Given this list of marker genes NFKBIA, DHRS3, ADCY1, NR4A3, PTGDS, ICAM1, CXCL3, SNED1, COL21A1, CXCL8, GCH1, MAP3K8 (NCBI Gene Id 8040), ADH1B, EGR1 (early growth response 1), FYB1, ADH1C, ATF3, CFD, APOE, CHRDL1, VWA5A, SLC29A1, SSX2, RARRES2, IGF2, TMEM265, RGS2, ATP1A2, ERP44, NR4A1, ECPAS, MFAP4, DAZL, NR4A2, ELANE, ADH1A, IRF1, FOS, N4BP2L1, ECM2, here is a description of the gene set: studied in species Homo sapiens Genes up-regulated in primary fibroblast cell culture point after infection with HCMV (AD169 strain) at 2 h time point that were not up-regulated at the previous time point, 1 h. from publication Browne EP, Wing B, Coleman D, Shenk T (PMID 11711622) Human Gene Set: BROWNE_HCMV_INFECTION_2HR_UP The effect of human cytomegalovirus (HCMV) infection on cellular mRNA accumulation was analyzed by gene chip technology. During a 48-h time course after infection of human diploid fibroblasts, 1,425 cellular mRNAs were found to be up-regulated or down-regulated by threefold or greater in at least two consecutive time points. Several classes of genes were prominently affected, including interferon response genes, cell cycle regulators, apoptosis regulators, inflammatory pathway genes, and immune regulators. The number of mRNAs that were up-regulated or down-regulated were roughly equal over the complete time course. However, for the first 8 h after infection, the number of up-regulated mRNAs was significantly less than the number of down-regulated mRNAs. By analyzing the mRNA expression profile of cells infected in the presence of cycloheximide, it was found that a minimum of 25 mRNAs were modulated by HCMV in the absence of protein synthesis. These included mRNAs encoded by a small number of interferon-responsive genes, as well as beta interferon itself. Cellular mRNA levels in cytomegalovirus-infected cells were compared to the levels in cells infected with UV-inactivated virus. The inactivated virus caused the up-regulation of a much greater number of mRNAs, many of which encoded proteins with antiviral roles, such as interferon-responsive genes and proinflammatory cytokines. These data argue that one or more newly synthesized viral gene products block the induction of antiviral pathways that are triggered by HCMV binding and entry.